The following is a description of a gene set: Morphogenesis, during the embryonic phase, of a tissue or tissues that work together to perform a specific function or functions. Morphogenesis is the process in which anatomical structures are generated and organized. Organs are commonly observed as visibly distinct structures, but may also exist as loosely associated clusters of cells that work together to perform a specific function or functions. Human Gene Set: GOBP_EMBRYONIC_ORGAN_MORPHOGENESIS species: Homo sapiens, and this is the list of marker genes: NKX3-2, HESX1, STRC, BLOC1S5, SOX11, DNAAF1 (NCBI Gene Id 123872), FGF10, CITED2, BCR, FGFR1, IHH, NPHP3, LBX1, SMO, GRHL2, FOXI1, ZIC3, PDZD7, FUZ, YAP1, HAND2, TECTA, HOXA11, SPARC, SCRIB, MTHFD1 (methylenetetrahydrofolate dehydrogenase, cyclohydrolase and formyltetrahydrofolate synthetase 1), EDNRA, PITX2, ALX1, MEGF8, MYO3A, HOXB4, NOG, SRF, TRIOBP, APLNR (apelin receptor), BBS7, BMP4, MESP1, ASB2, HMX2, FOXN4, TCAP, LRIG3, KCNQ4, OSR1, FZD5, FOXC2, NCKAP1, STRA6, CHD7, OSR2, ARL13B, NKX2-5, HOXA2, SOX9, WDR19, GLI1, SUFU, SHOX2, CLRN2, TMIE, MYO7A, HIF1A, RARG, HOXA5, FBN2, GLI3, HOXB2, TGFBR1, LHX1, FGF9, LRIG1, DLG1, BMI1, HOXC11, EYA1, SATB2, ITGA8, FRS2, SOD1, DLX6, ID2, TBX3, RARB, MFAP2, NHERF1, TIFAB, SP3, FRZB, HOXA4, SIX3, POU4F3, MYCN, AHI1, WDPCP, IFT140, EIF4A3, RBPMS2 (NCBI Gene Id 348093), WNT1, NEUROD1 (neuronal differentiation 1), WNT16, ALDH1A3, SOX17, SETDB2, PRRX1 (NCBI Gene Id 5396), SHH, HOXA1, FZD3, MYO3B, GATA3, NOTO, TBX20, RUNX2, CRB2 (NCBI Gene Id 286204), SIX2, HOXD11, ANKRD24, TBX2, PAX8, TWIST1, SEC24B (NCBI Gene Id 10427), HOXB7, KCNQ1, RYR2, NECTIN1, PCGF2, PRKRA, DLL1, INSIG1, CCDC39, MEF2C, TBX15, FOXL2, BBS5, RAC1, ALX4, TEAD2, HOXD4, RDH10, MED12, CEP290, REST, MMP14, NR4A3, MIB1, FGF8, IFT57, HOXB6, USH1C, HIPK2, GATA4, VAX2, TSHZ1 (NCBI Gene Id 791257), ZIC1, PAX2 (paired box 2), EFEMP1, HAND1, HOXA9, ATP6V1B1, SIX1, HOXD10, HOXB1, HMX3, DVL1, EPHA2, PAX5, PSEN1, SMAD3, IRX5, USH1G, IFT52, ACVR1, NIPBL, MDFI, ATP8A2, TGFBR2, CLRN1 (clarin 1), FOXF2, FLVCR1, DLX2 (NCBI Gene Id 1746), SOBP, LHFPL5, PPP1R35, MAPK1, CTNNB1, TBX18, SMAD2, MYO6, MYC, MAFB, CRYAA (crystallin alpha A), HOXC4, MYF5, NAGLU, NDRG4, GJB6, GRXCR2, HES1, MSX1, NOTCH1, ALX3, STIL, GSC, HOXA3, HYAL1 (NCBI Gene Id 3373), POU3F4, TTC39C, SLC44A4, GATA2 (NCBI Gene Id 84724), MAPK3, CHRNA9, CCDC40 (coiled-coil domain 40 molecular ruler complex subunit), EDN1, HOXB3, FBN1, HOXD3, OTX1, SOX18, HOXB5, SPRY2, IFT172, PKD2, TCF21, NDST1, PLS1, DSCAML1, ZEB1, MKKS, COL2A1, FOXG1, EPHB2, STOX1, C2CD3, HOXC9, PROX1, SLITRK6, HPN, MFAP5, MTHFD1L, COL11A1, DYNC2I1, FGFR2, CLUAP1, WNT3A, WHRN, GBX2 (NCBI Gene Id 2637), NODAL, TFAP2A, NECTIN3 (nectin cell adhesion molecule 3), SLC39A1, CHRNA10, TBX1, TMED2, FZD2, CCDC103, CDH23, MICAL2, RNF207, FOXH1, CHST11, NOTCH2, PHACTR4, FZD6, FOLR1, DLX5, DVL2, FOXF1, EFNA1, PTK7, VANGL2, CTHRC1, HOXA7, HOXB9, HNF1B, FOXE1, DCANP1, RBP4 (NCBI Gene Id 5950), RPL38, NEUROG1, TH, ENG, WNT9B, OVOL2, GRXCR1, WNT5A, BMP7, PDGFRA, WNT11, ATOH1, OTOP1, INSIG2, HLX, HOXD9, KDM2B, GRHL3, HIPK1, TULP3, MYO15A, SIX4, MMP16, SLC39A3, TPRN, PAX6, NTN1, HOXB8